The following is a description of a gene set: from publication Chen Y, Wang X (PMID 31504780) Human Gene Set: MIR200C_5P species: Homo sapiens Genes predicted to be targets of miRBase v22 microRNA hsa-miR-200c-5p in miRDB v6.0 with MirTarget v4 prediction scores > 80 (high confidence targets)., and this is the list of marker genes: HIVEP1, HEPHL1, EML1, MTM1, SMAD5, PCDH8, CAVIN2, PLXDC2, MAPK6, CPXCR1, HECA, ZNF792, SYNCRIP, PTGIS, SERINC5, SLC16A14, PLEKHF2, MEAF6, IL7, VASN, JMY, PHACTR2, CPEB2, HS3ST3B1, SMARCD2, CCNT1, C1orf94, HOXA4, UTP15, GNG13, DTNA, ATP1A2, IRAK1BP1, GNAO1 (G protein subunit alpha o1), PSMD14, MSRB3, ARID4B, ZNF14, COL11A1, PAK3, CAPRIN1, CNIH1, SEMA4F, POTEF, MEF2C, GNAI3, MYT1L, MLANA, PITPNC1, INA, ZBTB8A, THBD, GARIN2, DCDC2, PCDH17, C19orf44, SLC25A13, ZNF763, RUNDC3B, SYT4, MYH10, RAP1A, CD47